The following is a description of a gene set: A quatrefoil tethering complex required for retrograde traffic from the early endosome back to the late Golgi and biogenesis of cytoplasmic vesicles. species: Mus musculus Mouse Gene Set: GOCC_GARP_COMPLEX, and this is the list of marker genes: Vps54, Eipr1, Vps52, Vps53, Vps51